The following is a description of a gene set: studied in species Homo sapiens Human Gene Set: GOBP_PROTEIN_AUTOPROCESSING Processing which a protein carries out itself. This involves actions such as the autolytic removal of residues to generate the mature form of the protein., and this is the list of marker genes: FXN, MYRFL, TMPRSS2, HTRA2, DHH, HJV, PISD, CTSL (cathepsin L), PCSK2, CASP4, PIDD1, CASP1, MYRF, OMA1, SPRTN, CAPN2, PARP1, CASP6, PCSK9, F12, FAM111A, AFG3L2 (AFG3 like matrix AAA peptidase subunit 2), SHH, KLK6, IHH